The following is a description of a gene set: Catalysis of the reaction: 4 ATP + 2 phosphorylase b = 4 ADP + phosphorylase a. species: Mus musculus Mouse Gene Set: GOMF_PHOSPHORYLASE_KINASE_ACTIVITY, and this is the list of marker genes: Phkg2, Prkag2, Elp4 (elongator acetyltransferase complex subunit 4), Phkg1, Elp3